The following is a description of a gene set: species: Homo sapiens EGFR Transactivation by Gastrin Human Gene Set: REACTOME_EGFR_TRANSACTIVATION_BY_GASTRIN, and this is the list of marker genes: PRKCA, HBEGF, SOS1, KRAS, EGFR, GRB2, MMP3, NRAS, HRAS